The following is a description of a gene set: Mouse Gene Set: CUI_CDC1_IL1RA_RESPONSE_DN from publication Cui A, Huang T, Li S, Ma A, Pérez JL, Sander C, Keskin DB, Wu CJ, Fraenkel E, Hacohen N (PMID 38057668) species: Mus musculus Cytokines mediate cell-cell communication in the immune system and represent important therapeutic targets. A myriad of studies have highlighted their central role in immune function, yet we lack a global view of the cellular responses of each immune cell type to each cytokine. To address this gap, the authors created the Immune Dictionary, a compendium of single-cell transcriptomic profiles of more than 17 immune cell types in response to each of 86 cytokines (>1,400 cytokine-cell type combinations) in mouse lymph nodes in vivo. A cytokine-centric view of the dictionary revealed that most cytokines induce highly cell-type-specific responses. For example, the inflammatory cytokine interleukin-1β induces distinct gene programmes in almost every cell type. A cell-type-centric view of the dictionary identified more than 66 cytokine-driven cellular polarization states across immune cell types, including previously uncharacterized states such as an interleukin-18-induced polyfunctional natural killer cell state. Genes negatively differentially expressed in cell type: cDC1 (conventional dendritic cell type 1) upon treatment with cytokine: IL-1Ra in mouse lymph nodes in vivo., and this is the list of marker genes: Tsc22d3, Uba52, Hspa1a, Hspa1b, Klf2